The following is a description of a gene set: Mouse Gene Set: GOBP_REGULATION_OF_VASCULAR_ASSOCIATED_SMOOTH_MUSCLE_CELL_DIFFERENTIATION studied in species Mus musculus Any process that modulates the frequency, rate or extent of vascular smooth muscle cell differentiation., and this is the list of marker genes: Gper1, Cth, Fgf9, Sod2, Nfatc3, Eng, Nfatc1, Hey2, Pdgfb, Pdcd4, Dnmt1, Efemp2, Kit, Nfatc2 (nuclear factor of activated T cells, cytoplasmic, calcineurin dependent 2)